The following is a description of a gene set: Mouse Gene Set: GOMF_MAP_KINASE_ACTIVITY Catalysis of the reaction: protein + ATP = protein phosphate + ADP. This reaction is the phosphorylation of proteins. Mitogen-activated protein kinase; a family of protein kinases that perform a crucial step in relaying signals from the plasma membrane to the nucleus. They are activated by a wide range of proliferation- or differentiation-inducing signals; activation is strong with agonists such as polypeptide growth factors and tumor-promoting phorbol esters, but weak (in most cell backgrounds) by stress stimuli. studied in species Mus musculus, and this is the list of marker genes: Mapk10, Mapk11 (NCBI Gene Id 19094), Mapk15, Mapk7, Mapk8, Nlk, Mapk3, Map3k7, Mapk14, Mapk12, Mapk1, Mapk4, Mapk9, Mapk6, Map2k7, Mapk13